Given this list of marker genes MAPRE1, KIF18A, CCSAP, PAFAH1B1, NUMA1, FAM161A, KIF18B, MISP, MAP9, DYNLT3, MAPRE3 (NCBI Gene Id 22924), here is a description of the gene set: studied in species Homo sapiens Human Gene Set: GOCC_ASTER An array of microtubules emanating from a spindle pole MTOC that do not connect to kinetochores.